The following is a description of a gene set: from publication Chen Y, Wang X (PMID 31504780) Human Gene Set: MIR6778_3P Genes predicted to be targets of miRBase v22 microRNA hsa-miR-6778-3p in miRDB v6.0 with MirTarget v4 prediction scores > 80 (high confidence targets). studied in species Homo sapiens, and this is the list of marker genes: PXMP4, DDX5, PRICKLE1, SNX11, STX18, CDC37L1, SAMD14, ZNF704, EPG5, CEP97, MFSD11, SLC7A11, RPL13, RGS16, MAN2A2, ZBTB8A, UPP2, POLH, IRGQ, NUDT18, STEEP1, ZNF264, IBA57, ADCY5, IRF1, SPN, CACNG8, LAMP1, TCTA, DCP2, NFX1, CTSB, PTK7, KLHL13, TPM3, HGSNAT, SPIRE2, GATAD1, HAUS2, MARVELD3, DNASE2, ZNF316 (zinc finger protein 316), PTAFR, TPRG1L, CBX2, CGNL1, PROX1, DBT, SLC31A1, MCUR1, CYP27C1, SLC52A3, BAK1, ENTPD1, LRRC57, MTCL2, LRRC74B, DCAF16, SKP1, FBXO27, PLEKHA5, THY1, AP1S3, EDEM3, RAB3B, FAM3A, ZBTB21, DNAJC3, PEX5L, ORAI2, ZNF530, DHDDS, SLC38A3, MIGA1, FBXO9, CBLL1, OPA3, SNRPD3, C17orf75, DDX51, MSI2, KCNC1, CCL5, CCDC157, ERVV-1 (endogenous retrovirus group V member 1, envelope), USP49, GIN1, ARHGAP30, FXR2, UGGT1, GTF2H2 (NCBI Gene Id 2966), B3GNT6, RBL1, ZNF667, UBL7, SPIB, SYT2, FURIN, DEGS1, FAM227A, CFLAR, SWSAP1, AP5B1, METTL2A, DNAJB2, SMUG1, MEDAG, TADA2B, AAK1, MMACHC, ZSWIM1, RSL1D1, ZNF696, ST3GAL1, NMNAT1, SLC43A2, GATD1, TTC23L, DCAF7, RRP7A, ZKSCAN1 (NCBI Gene Id 7698), BICRAL, TPD52L3, GON4L, CD96, C5AR1, GPR85, FAIM2 (NCBI Gene Id 26294), TLCD2, ZNF793, ZNF714, PGPEP1, SLC46A3, OAZ2, PLEKHM3, CAMK1D, GPR155, KREMEN1, ZC4H2 (zinc finger C4H2-type containing), VPS53 (NCBI Gene Id 55275), FNBP1, FAM184B, TAF9B, ATP1B1, CCDC142 (coiled-coil domain containing 142), ATP6V0B, DUXA, ZMYND19, PREPL, ZNF791, PLA2G12B, DHTKD1, CYP20A1, NME6, UNKL, CABP4, ANKH, MR1, PTPN2, ZFP82, GLB1L (NCBI Gene Id 79411), SLC50A1, TTPAL, EHD1 (EH domain containing 1), JRK, SRSF3, CPM, FAM219A, NRP2, GTF2H5, APC, DNAAF10, LPP, DFFA, SYT7, ABI2, KCND1, CRX, BLZF1, KIAA1614, PRELP, ATCAY, LCTL, ZNF114, FAM131A, CCBE1, SMCR8, KIF1C, ZNF417, IL17RA, ZFR2, PHAX, ADAM11, PPM1F, XXYLT1, STK32A, IPO9, LDLR (NCBI Gene Id 3949), DSTYK, PRR11, GK5, BCDIN3D, CPLX4, SMIM14, PIANP, EFCAB11, PDE4C, SLC35E4, GPR82, PIGBOS1 (PIGB opposite strand 1), ADCY1, CLEC7A, GOSR2, ITPRID1, TMC5, VPS26B, MRPL57, XIAP, PLEKHG4B (pleckstrin homology and RhoGEF domain containing G4B), RTP1, CWC25, CAVIN1